Given this list of marker genes Ngf, Map2k2, Frs2, Mapk3, Map2k1, here is a description of the gene set: This event has been computationally inferred from an event that has been demonstrated in another species.<p>The inference is based on the homology mapping from PANTHER. Briefly, reactions for which all involved PhysicalEntities (in input, output and catalyst) have a mapped orthologue/paralogue (for complexes at least 75% of components must have a mapping) are inferred to the other species. Reactome Pathway: Frs2-mediated activation electronically inferred by orthology from the curated human pathway part of: Prolonged ERK activation events species: Mus musculus